The following is a description of a gene set: Human Gene Set: GAZDA_DIAMOND_BLACKFAN_ANEMIA_PROGENITOR_UP from publication Gazda HT, Kho AT, Sanoudou D, Zaucha JM, Kohane IS, Sieff CA, Beggs AH (PMID 16741228) Genes up-regulated in common hematopoietic progenitor cells isolated from bone marrow of patients with Diamond-Blackfan anemia (DBA) and mutated RPS19. species: Homo sapiens Diamond-Blackfan anemia (DBA) is a broad developmental disease characterized by anemia, bone marrow (BM) erythroblastopenia, and an increased incidence of malignancy. Mutations in ribosomal protein gene S19 (RPS19) are found in approximately 25% of DBA patients; however, the role of RPS19 in the pathogenesis of DBA remains unknown. Using global gene expression analysis, we compared highly purified multipotential, erythroid, and myeloid BM progenitors from RPS19 mutated and control individuals. We found several ribosomal protein genes downregulated in all DBA progenitors. Apoptosis genes, such as TNFRSF10B and FAS, transcriptional control genes, including the erythropoietic transcription factor MYB (encoding c-myb), and translational genes were greatly dysregulated, mostly in diseased erythroid cells. Cancer-related genes, including RAS family oncogenes and tumor suppressor genes, were significantly dysregulated in all diseased progenitors. In addition, our results provide evidence that RPS19 mutations lead to codownregulation of multiple ribosomal protein genes, as well as downregulation of genes involved in translation in DBA cells. In conclusion, the altered expression of cancer-related genes suggests a molecular basis for malignancy in DBA. Downregulation of c-myb expression, which causes complete failure of fetal liver erythropoiesis in knockout mice, suggests a link between RPS19 mutations and reduced erythropoiesis in DBA., and this is the list of marker genes: ATP6V1B2 (NCBI Gene Id 526), LST1, SLC2A3, NAMPT, CAVIN1, MAFF, GGPS1, LEPROT (leptin receptor overlapping transcript), HLA-G, CREM, MRFAP1L1, BAX, CD83, SEMA4D, DHRS1, VPS13D, RRAS2, SUPT4H1, STAT4, CHMP1B, SDAD1 (SDA1 domain containing 1), WIPF2, HLA-DPA1, ANXA5, ZBTB44, FGF9, FTH1, GABBR1, VNN2, MAP2K4, PDE10A, SDHC, NACC2, RAB21, DNM3, HLA-DQA1, IRF9, U2AF1, FXYD6